The following is a description of a gene set: Catalysis of the reaction: triacylglycerol + H2O = diacylglycerol + a carboxylate, where the triacylglycerol is part of a lipoprotein. May also hydrolyze diacylglycerol and phospholipids present in lipoproteins. species: Homo sapiens Human Gene Set: GOMF_LIPOPROTEIN_LIPASE_ACTIVITY, and this is the list of marker genes: APOA5, LIPK, LIPM, APOH, DAGLA, PNLIPRP1, PNLIPRP2, GPIHBP1, LIPN, LIPG (lipase G, endothelial type), APOC2, PNPLA3, PNLIP, PNPLA2, LPL, PNLIPRP3 (pancreatic lipase related protein 3), LIPC